The following is a description of a gene set: species: Homo sapiens Genes having at least one occurrence of the motif NNGTAAKTNG in the regions spanning 4 kb centered on their transcription starting sites. This matches the TLX2 transcription factor binding site V$NCX_01 (v7.4 TRANSFAC). Human Gene Set: NCX_01, and this is the list of marker genes: RPL4 (ribosomal protein L4), ROBO3, BDNF, HBP1, ABHD17B, HOXD3, DUSP2, ZNF532, PTCHD4, PRKACA, CHCHD7, WDPCP, MINDY2, LTB4R2, TRIM62, HOXA4, DLG2, NXF1, BMX (NCBI Gene Id 660), TXNL4B (thioredoxin like 4B), NUFIP2, SNCAIP, SLC24A4, LRRC8A (leucine rich repeat containing 8 VRAC subunit A), ERG, RBM4, BCOR, PPP4R3B, LCE1F, TNPO3, SSR1, DNAJC7, RPP21, DCX, BMP5 (NCBI Gene Id 653), HOXC6, CTCF, NRXN1, OTX2, PAX1, PLAG1, IMMP2L, NKIRAS2, ELAVL4, GPC3, PEG3, SETD2, MMP14, RNF11, KCND2, IL13RA1, A2M, CELA1, HNF1A, MAP4K4, AHNAK, PITPNM2, PTPN4, TBR1, DHX38, SPIC, EMC9, THRA, PAN2, SREK1, ARHGAP6, RUNX1, SH3BGRL2, WNT5A, CCDC6, LPAR4, ING3, GNG4, APPBP2, PAK1IP1 (PAK1 interacting protein 1), GATA4, GNAS, ITGA3, EMX2, ELAVL2, TUT1, MOV10, RNF186, NOS1, ATP1A3, USPL1, SESN3, CDX2, CADM1, TPI1P2 (NCBI Gene Id 392986), HAPLN1, UBR5, PPP1R16A, ISL1, CIDEB, HOXC4, JADE2, DCDC1, KLF4, PHOX2B, LMO3, WNT11, NR2F1, ANKRD28 (ankyrin repeat domain 28), JADE1, SYNRG, DUSP14, ATP8B4, CLDN17, PTCH2, ZIM2 (NCBI Gene Id 23619), TRPV6, MINK1, PHF12, MEPCE, P2RY6 (NCBI Gene Id 5031), RFX3, PRKAB1, ANK2, SAV1, GAP43, MORF4L2, CACNA2D2, SLC6A14, DYNLL1 (dynein light chain LC8-type 1), UBE2K (ubiquitin conjugating enzyme E2 K), IP6K2, ETV6, PDZRN4, SLAIN1, CDH6, PLAGL1, NUP153, EVX1, ESR1, FEZF2, LMO1, ETV1, FOXD3, CA10, SDK2, MSRB3, PCDH9, ZCWPW1, FIBIN, ERLIN2, PTK2B, PKHD1, RNF43, PLXNC1 (plexin C1), JAML, TFIP11, HOXC11 (homeobox C11), NRAP, ASCL3, MAP4, SEPTIN9, KMT2E, NRAS (NCBI Gene Id 4893), NEUROD6, PAX3, SEMA5B, PDZD2, SP7, KLF12, EOMES, CDC14A, RAB39A, FAM53C, RAB35, MEIOB, RPP25, CCDC140, SLC1A7, CNOT1, SPTLC2